The following is a description of a gene set: species: Homo sapiens Human Gene Set: GOBP_DEADENYLATION_DEPENDENT_DECAPPING_OF_NUCLEAR_TRANSCRIBED_MRNA Cleavage of the 5'-cap of a nuclear mRNA triggered by shortening of the poly(A) tail to below a minimum functional length., and this is the list of marker genes: CAPRIN1, LSM1, DCP1A, CNOT7, NOCT, DCP2, PATL1, EIF4ENIF1, PATL2, DCPS, PAN3, DCP1B